The following is a description of a gene set: species: Homo sapiens Human Gene Set: ROAZ_01 Genes having at least one occurrence of the motif GCACCCAWGGGTGM in the regions spanning 4 kb centered on their transcription starting sites. This matches the ZNF423 transcription factor binding site V$ROAZ_01 (v7.4 TRANSFAC)., and this is the list of marker genes: HEBP2, CDKN1A, PPP1R16A, RASAL2, RCOR2, DUSP7, FBXO32, TIMM50, BEX1, LRATD1, BEX3